Given this list of marker genes HTR1E, HTR4, HTR1F, HTR1A, HTR7, HTR5A, HTR2B, HTR2C, HTR6, HTR2A (NCBI Gene Id 3356), HTR1D, HTR1B (5-hydroxytryptamine receptor 1B), here is a description of the gene set: studied in species Homo sapiens Human Gene Set: REACTOME_SEROTONIN_RECEPTORS Serotonin receptors